The following is a description of a gene set: species: Mus musculus A process that is carried out at the cellular level which results in the assembly, arrangement of constituent parts, or disassembly of cytoskeletal structures containing both actin and myosin or paramyosin. The myosin may be organized into filaments. Mouse Gene Set: GOBP_ACTOMYOSIN_STRUCTURE_ORGANIZATION, and this is the list of marker genes: Tgfb3, Cdc42bpa, Cdc42, Nrp1, Cavin4, Arrb1, Cnn2, Carmil1, Arhgap6, Myh9, Arhgef15, Fermt2, Prkar1a, Hdac2, Lurap1, Asap3, Myh6, Src, Cdc42bpb, Myom1, Bbs4, Nrap, Iqgap2, Arhgap28, Myh10, Mtor, Spag6l, Abl1, Iqgap3, Tacr1, Dlc1, Myl2, Tmod2, Frmd5, Mybpc1, Coro2b, Myoz1, Gpr65, Phactr1, Myom3, Ldb3, Plec, Neurl2, Zyx, Epb41l1, Srf, Bmp10, Fhdc1, Limk1, Kctd13, Cdc42bpg, Cflar, Mfn2, Mkks, Akap13, Rhpn1, Itgb5, Zeb2, Arap1, Braf, Tac1, Casq2, Fhod1, Iqgap1, Tmod3, Eln, Ttc8, F11r (NCBI Gene Id 226655), Epb41, S100a10, Stmn1, Prox1, Smad3 (SMAD family member 3), Wnt4, Itgb1bp1, Rock1, Krt19, Kank2, Pik3r2, Apoa1, Clasp1, Capn3 (calpain 3), Ect2, Cd47, Myoc, Ptger4, Pak2, Synpo, Csrp1, Luzp1, Dnm2, Epb41l2, Sh3pxd2b, Ppfia1, Ptk2b, Nebl, Wasf2, Racgap1, Inpp5k, Rock2, Phldb2, Pfn1, Limch1, Edn1, Lmod3, Tnnt3, Kank3, Arhgef10, Actg1, Pdgfrb, Rgcc, Clasp2, Tgfbr1, 4930544G11Rik, Pgm5, Alkbh4 (NCBI Gene Id 72041), Fhod3, Itgb1, Pxn, Mef2c, Was, Rhpn2, Sdc4, Mef2a, Tmsb15b2, Adprhl1, Tmsb15l, Six4 (NCBI Gene Id 20474), Pdlim1, Epb41l4a, Pdlim4, Tnnt2, Csrp3, Ccdc88a, Pdcd6ip, Anln, Trpm7, Sorbs1, Evl, Tjp1, Myh11, Tesk1, Cgnl1, Frmd3, Lpar1, Myoz2, Lmod1, Ppm1e, Tnnt1, Flnc, Neb, Tmeff2, Tmod1, Smad4, Tsc1, Xirp1 (xin actin-binding repeat containing 1), Rac1, Arhgef18, Cnn1 (calponin 1), Ttn, Fam171a1, Mybpc3, Flii, Mypn, Rtkn, Mybph, Krt8, Prkcq, Epha1, Pfn2, Tnfaip1, Ppp1r9a, Epb41l4b, Actn2, Rapgef3, Mybpc2, Pik3r1 (NCBI Gene Id 328326), Kiss1r, Serpinf2, Acta1, Pak1, Cul3 (NCBI Gene Id 98674), Tmod4, Ppm1f, Cnn3 (NCBI Gene Id 97105), Tpm1, Nf2, Cfl2, Cav3, Lmod2, Klhl41, Pdgfra, Myo18b, Ccn2, Prkd1, Met, Wdr1, Myl9, Actc1, Nkx2-5, Ep300, Kank4, Frmd7, Alms1, Ankrd23, Rhoa, Tacstd2, Wnt11, Epb41l5, Rhoc, Sorbs3, Epb41l3, Bag4, Arhgef5, Tcap, Myom2, Casq1, Myo18a, Nox4, S1pr1, Myh14, Synpo2l, Csrp2, Mylk3, Arhgef10l